The following is a description of a gene set: The process in which an endocardial cushion cell becomes a cell of a cardiac septum. species: Mus musculus Mouse Gene Set: GOBP_CARDIAC_SEPTUM_CELL_DIFFERENTIATION, and this is the list of marker genes: Tbx5, Kcnj8, Nkx2-5, Bmpr1a, Maml1